The following is a description of a gene set: A partial or complete breakage of the continuity of a bone. Human Gene Set: HP_BONE_FRACTURE Bone fracture species: Homo sapiens, and this is the list of marker genes: FGF23, SLC2A2, TRPV6, EXT2, BICD2, LEMD2, MOGS, CLCN7, EXT1, TCIRG1, XYLT2, LBR, UBA1, TBCD, TNFRSF11A, TAPT1, ANAPC1, GALT, MTAP (methylthioadenosine phosphorylase), ATL3, SQSTM1, GNAS